Given this list of marker genes RARRES1, CFI, HP, NR4A2, ST6GAL1, ALDH2, BTG2, here is a description of the gene set: Top genes higher expressed in long term mesothelioma survivors. Human Gene Set: LOPEZ_MESOTELIOMA_SURVIVAL_TIME_DN species: Homo sapiens from publication López-Ríos F, Chuai S, Flores R, Shimizu S, Ohno T, Wakahara K, Illei PB, Hussain S, Krug L, Zakowski MF, Rusch V, Olshen AB, Ladanyi M (PMID 16540645) Most gene expression profiling studies of mesothelioma have been based on relatively small sample numbers, limiting their statistical power. We did Affymetrix U133A microarray analysis on 99 pleural mesotheliomas, in which multivariate analysis showed advanced-stage, sarcomatous histology and P16/CDKN2A homozygous deletion to be significant independent adverse prognostic factors. Comparison of the expression profiles of epithelioid versus sarcomatous mesotheliomas identified many genes significantly overexpressed among the former, including previously unrecognized ones, such as uroplakins and kallikrein 11, both confirmed by immunohistochemistry. Examination of the gene expression correlates of survival showed that more aggressive mesotheliomas expressed higher levels of Aurora kinases A and B and functionally related genes involved in mitosis and cell cycle control. Independent confirmation of the negative effect of Aurora kinase B was obtained by immunohistochemistry in a separate patient cohort. A role for Aurora kinases in the aggressive behavior of mesotheliomas is of potential clinical interest because of the recent development of small-molecule inhibitors. We then used our data to develop microarray-based predictors of 1 year survival; these achieved a maximal accuracy of 68% in cross-validation. However, this was inferior to prognostic prediction based on standard clinicopathologic variables and P16/CDNK2A status (accuracy, 73%), and adding the microarray model to the latter did not improve overall accuracy. Finally, we evaluated three recently published microarray-based outcome prediction models, but their accuracies ranged from 63% to 67%, consistently lower than reported. Gene expression profiling of mesotheliomas is an important discovery tool, but its power in clinical prognostication has been overestimated.